The following is a description of a gene set: species: Mus musculus Mouse Gene Set: GOBP_EXTRACELLULAR_TRANSPORT The transport of substances that occurs outside cells., and this is the list of marker genes: Dnah5, Ccdc88c, Cfap221, Dydc1, Nme7, Cfap43, Cwh43, Rfx3, Megf8, Dnaaf4, Stk36 (NCBI Gene Id 73581), Spef2, Spag6l, Dnaaf2, Rsph14, Rsph1, Dnah9, Ak7, Ttll1, Spag16, Dpcd, Gmnc, Daw1, Jhy, Dnaaf3, Ropn1l, Kif27, Gas8, Katnip, Cfap45, Cfap53, Rsph3b, Aqp4, Arrdc1, Spag6, Stard7, Adcy10, Nek10, Ofd1, Dnaaf11, Dnajb13, Cfap54, Dnah11, Ccdc40, Invs, Wwp2, Ccdc39, Nherf1, Iqub (IQ motif and ubiquitin domain containing), Odad4, Dnai1, Nme5, Tsg101, Odad3, Rsph4a, Spag17, Dnah1, Drc1, Ccdc103, Vangl1, Rsph9, Ulk4